Given this list of marker genes SKI, ZNF280C, ELP3, RERG, LMNB2, FRMD8, TTC4, LEPROT, RETREG2, CSNK1D, PAG1, PANX1, RBM5, RGS19, KANSL2 (KAT8 regulatory NSL complex subunit 2), PEMT, SMARCD2, NDUFB11, GBP7, MRPL28, DNAJC9 (DnaJ heat shock protein family (Hsp40) member C9), TUBGCP5, ZKSCAN3, TRIM11, MCM7 (minichromosome maintenance complex component 7), TADA1, HPF1, UMOD, TUBGCP3, SH3BP5L, MTARC2, ENPP3, DLG1, COMT, CD79B, MPHOSPH9, IL6R, YEATS4, HPCAL1, AVP, ANKRD10, CTNNA1, HCFC1, SIX4, RNASE4, FKBP4, PCNX3, EEF1B2, SOBP, PIAS3, SRCAP, LCLAT1, MGST2, HLX, NRIP1, ERCC8, ATM, PHF5A, CCT5, THRB, ANP32B, DCTN4, RNF187 (NCBI Gene Id 149603), EMID1, FBXO8 (F-box protein 8), TRIM3, STARD3NL, VPS37A, SLC4A1AP (NCBI Gene Id 55189), SFTPC, EPAS1, CCR2, COL17A1, KCNN4, PLEKHA1, BCAP29, PCYOX1, ANKRD28, RBFOX3, ADD1, NCOR1, SART3, TAF5L, CPA5, KRI1 (NCBI Gene Id 65095), HSPBP1, RRP36, UBXN1, HMBS, AKAP8, MLYCD, C15orf40, ACOT8, WDR33 (WD repeat domain 33), PACC1, SIPA1, NAGK, CEP20, YAE1, MSN, FKBP1B, KCTD11, CAMK2G, RDH13, HHEX, TOMM20, CDK20, TMEM30A, KAT7, DFFB (DNA fragmentation factor subunit beta), HMCES, SCEL, SLF2, CNN3, RALBP1, ACO1, SNAPC2, HMGCL, ARID1A, C6orf136 (NCBI Gene Id 221545), LUC7L3, CPLX4, DHX36, TSR1, CNOT6L, AGBL5, ELP2, NAA35, FLT3LG, CLPTM1L, PCDH18, ERCC6L, SMC2, PRKCD, CERS5, PNPLA6, EDEM3, MPP1, CACYBP, TBCE, BDH1, C14orf119, FAM53A, PPIL4, TMEM192, MTFMT, KLF10, SLC25A4, CNOT9, PEX11B, ALDOAP2 (NCBI Gene Id 228), ABCD2, NANP, SHMT2, ELAC1, CASP6, CCDC127, OSBP, ZFP91, EXT2, MINDY1 (NCBI Gene Id 55793), TF, HEBP1, ZIC1, PEPD, PISD, ATP5PF, MED22, NDUFC2 (NADH:ubiquinone oxidoreductase subunit C2), TMEM51, SVIL, NUP35, OSBPL11, MOBP, TMEM191C, TMEM14C, SLC22A3, CDIPT, SAP30L, ABCD1, CCR6, TRAPPC14, NSUN4, POC5, KLHL9, MGAT2, SLC25A45, KTI12, HSCB, TOPBP1, C1orf174, PPP2R5A, ITFG1, SDHAF2, H2BC18, SLC39A3, TBL2, DRAM2, BTBD1, NSMCE4A, here is a description of the gene set: from publication Amit I, Garber M, Chevrier N, Leite AP, Donner Y, Eisenhaure T, Guttman M, Grenier JK, Li W, Zuk O, Schubert LA, Birditt B, Shay T, Goren A, Zhang X, Smith Z, Deering R, McDonald RC, Cabili M, Bernstein BE, Rinn JL, Meissner A, Root DE, Hacohen N, Regev A (PMID 19729616) mouse primary BMDCs were stimulated with tlr ligands and gene expression changes were profiled on Affymetrix arrays studied in species Homo sapiens Genes up-regulated in comparison of control dendritic cells (DC) at 2 h versus those stimulated with CpG DNA (TLR9 agonist) at 2 h. Human Gene Set: GSE17721_CTRL_VS_CPG_2H_BMDC_UP